The following is a description of a gene set: studied in species Homo sapiens Hypopigmented hair that appears white. White hair Human Gene Set: HP_WHITE_HAIR, and this is the list of marker genes: SLC45A2, NOP10, TGM3, PARN (NCBI Gene Id 5073), RTEL1, KITLG, GNPTAB, CTC1, TINF2, DKC1 (NCBI Gene Id 1736), MC1R (NCBI Gene Id 4157), TERT, TYR, OCA2, PAX3, TERC, NHP2, USB1, NPM1, PADI3, MYO5A, TYMS, WRAP53